Given this list of marker genes MED7, CCDC186, TNS2, DAP, NFYC, YWHAB, CHMP3, MERTK, SYNE1, SH3BGRL3, STARD4, HIPK1, HIGD2A, CTNND2, MIB2, MSH2 (NCBI Gene Id 8169), PFKM, DMPK, HSD17B11, HABP4, RIPOR1, SCAMP1, MYO7A, CRYBG3, TMEM109, SERPINB6 (serpin family B member 6), HELZ, MTSS1, ANKMY2 (NCBI Gene Id 96008), PRKAG2, C5orf34, CIB1, WDR45, RCN3, CCR9, GPI, CRIP2, CBFA2T3, H1-0, MGLL, AKAP8L, LCLAT1, PLEKHG2, CLU, SIDT2, TPRG1L, AMACR, ATP1B1, KLHL9, PAPSS1, FAM89B, PPM1B, HADH, PBX3, FBLN5, C16orf89, TSPAN9, SPSB3, ADD1, PEA15, PIP4K2A, COLGALT1, SCARB2, CROT, GBA2, NLK, SASH1, PCOLCE, RALBP1, SEPTIN4, SOX17, ABHD12, ABL1, ITPR3, WNT7A, ARHGAP21, MDP1, ETFBKMT, MAPK3, TSC22D4, GDI2, UNC119, KIF1C, DNASE1L1, ATRAID, MCOLN1, LZTR1, FHL1, GALNT1, ITGAX (NCBI Gene Id 3687), ETV1, NPRL2, PLP2, EML3, TECPR1, OTULINL, TCF3, PAK1, GSTK1, ABHD8, ZNF703, PPT1, MAGEE1, ITGAE, AP1B1, THAP11, KLRD1, TUSC3, BTBD1, VKORC1, FAM193B, PDE2A, VPS41, RCAN1, WAS, MAPK11, RSPH3, MEF2D, MMS19, ABHD14B, SCP2, MXD4, ING1, PANK1, PRELP, TLE5, TMEM37, NFATC3, RAB6B, CLEC14A, DAGLB, VCAM1 (NCBI Gene Id 7412), RAMP1, TTC3, GM2A, NDRG2, FBXL8, OLFM1, IDH1, CIAO3, LANCL1, BHLHE40, PISD, ARL2BP, ALDH2, RPS6KA1, PLPP1, SLC12A2, MYO9A, P2RY6, DYM, RECK, PALD1, CASC3, HEXIM1, NRF1, SELENOP, GLG1 (NCBI Gene Id 2734), AP1G2, CXXC5, MMP12, FAM43A, TOP2B, SERAC1, EMP3, ABI3BP, TIE1, S1PR4, STAMBPL1, LIPC, CCR6, ZSCAN26, EIF3F, STAB2, PTPRS, UGGT1, RAB3IL1, IL11RA, LDLRAP1, FAM8A1, KCTD12, CST3, TPCN1, GINM1, GSTM5, PRKCI, IMP3, HLA-DRB1, ADCY7, CALCRL, FGFR1, SELENBP1, SERPINA1, TNFRSF13C, SUOX, TRIO, PIH1D1, AS3MT, MAST3, PLD1, here is a description of the gene set: studied in species Homo sapiens Human Gene Set: GSE18281_SUBCAPSULAR_VS_PERIMEDULLARY_CORTICAL_REGION_OF_THYMUS_UP Genes up-regulated in thymus cortical regions: subcapsular versus perimedullary. from publication Griffith AV, Fallahi M, Nakase H, Gosink M, Young B, Petrie HT (PMID 20064453) Interaction of hematopoietic progenitors with the thymic stromal microenvironment induces them to proliferate, adopt the T cell fate, and asymmetrically diverge into multiple T lineages. Progenitors at various developmental stages are stratified among different regions of the thymus, implying that the corresponding microenvironments differ from one another, and provide unique sets of signals to progenitors migrating between them. The nature of these differences remains undefined. Here we use novel physical and computational approaches to characterize these stromal subregions, distinguishing gene expression in microdissected tissues from that of their lymphoid constituents. Using this approach, we comprehensively map gene expression in functionally distinct stromal microenvironments, and identify clusters of genes that define each region. Quite unexpectedly, we find that the central cortex lacks distinctive features of its own, and instead appears to function by sequestering unique microenvironments found at the cortical extremities, and modulating the relative proximity of progenitors moving between them.